The following is a description of a gene set: Human Gene Set: GOBP_ACTIN_MYOSIN_FILAMENT_SLIDING The sliding movement of actin thin filaments and myosin thick filaments past each other. species: Homo sapiens, and this is the list of marker genes: MYL11, MYL6B, MYH8, ACTC1, MYBPC3, MYLK2, MYH2, MYH7, TCAP, MYH3, TNNI3, TNNT2, TTN (NCBI Gene Id 7847), MYH6 (myosin heavy chain 6), MYH4, MYL6, TNNC1, TPM1 (tropomyosin 1), MYL1